The following is a description of a gene set: species: Homo sapiens Human Gene Set: GOBP_AMYLOID_PRECURSOR_PROTEIN_METABOLIC_PROCESS The chemical reactions and pathways involving amyloid precursor protein (APP), the precursor of amyloid-beta, a glycoprotein associated with Alzheimer's disease., and this is the list of marker genes: MIR17, MIR29B1, MIR298, PAWR, MIR455, EFNA1, CLN3, RELA, ADAM10, KLK6, SORL1, MIR106A, PSEN2, RTN1, LYN (LYN proto-oncogene, Src family tyrosine kinase), TMED10, GSK3A, BACE2, APOE, EFNA3, NECAB3, ROCK2, MIR15A, RTN2, MIR361, ADAM17, SPON1, RANBP9, SP1, IFNGR1, APH1B, LRRTM3, APP, MIR339, ADAM19, MIR31, MIR29A, FLOT2, TMCC2, MIR147A, TNF, MIR15B, SLC2A13, NTRK2, GGA3, ADAM9, ITM2B, SOAT1, DHCR24, DYRK1A, MIR24-1 (NCBI Gene Id 407012), LDLRAP1, ITM2A, MIR16-1, HAP1, MIR144, DLG1, RTN4, AGO2, NAGLU, MIR186, PSEN1, ABCG1, EPHA4, ABCA7 (NCBI Gene Id 82843), MIR520C, NECAB2, FKBP1A, CSNK1E, PRNP, ITM2C, AGER, PSENEN, MIR153-1, NCSTN, BACE1 (NCBI Gene Id 23621), PIN1, GSAP, IGF1, RTN3, APOA1, BIN1, PICALM, ROCK1, MIR323A, NECAB1, CHRNA7, MIR644A, NSG1, MIR107, MIR101-1, CLU, AATF, MIR20A, IFNG, ACHE, MIR103A1, MIR29C, APH1A, MIR206, CASP3, ABCA2